The following is a description of a gene set: A severe degree of muscular hypotonia characterized by markedly reduced muscle tone. Human Gene Set: HP_SEVERE_MUSCULAR_HYPOTONIA studied in species Homo sapiens Severe muscular hypotonia, and this is the list of marker genes: MPLKIP, MYMK, SNRPN, STRADA, TBC1D24, PGAP2, POMT2, PEX16, ZNHIT3, ITPA, LMOD3, KLHL40, GCH1, PEX10, GCDH, BMP4, LARGE1, DOLK, GPT2, ALG14, PEX19, UBA1, B3GALNT2, ACTA1, PNPT1, PEX11B, PEX3, PEX6, RMND1, TBCK, PIGG (NCBI Gene Id 54872), CCDC174, SLC25A12, NEB (nebulin), PEX14, PEX2, FKTN, POMT1, ASCC1, FKBP14, PEX12 (peroxisomal biogenesis factor 12), NDUFS6, MTM1, SLC39A8, B4GAT1, GRIN1, TPM3, AIFM1, PURA, DPM2, VAMP1, PEX5, FKRP, CARS2, POMGNT1, PIGN, TRIP4, SLC25A1, DMXL2, IBA57, BICD2, PEX26, KLHL41, PEX13, MPZ, PEX1